Given this list of marker genes DEF6, AAGAB, STK4, CD27, CDKN2A, STAT3, PGM3, CD70, ATM, MDM2, TP53, DKC1, FASLG, RNF43, FAS, SOCS1, ITK, POLE, COL14A1, TNFRSF9, CHEK2, MAGT1, KLHDC8B, CASP10, TCF4, here is a description of the gene set: Human Gene Set: HP_HODGKIN_LYMPHOMA A type of lymphoma characterized microscopically by multinucleated Reed-Sternberg cells. species: Homo sapiens Hodgkin lymphoma